The following is a description of a gene set: Human Gene Set: NRF2_Q4 studied in species Homo sapiens Genes having at least one occurrence of the motif NTGCTGAGTCAKN in the regions spanning 4 kb centered on their transcription starting sites. This matches the NFE2L2 transcription factor binding site V$NRF2_Q4 (v7.4 TRANSFAC)., and this is the list of marker genes: MGST1 (NCBI Gene Id 4257), PKN3, PFN2, ADCYAP1, KBTBD8, UBE2L3, CSNK1G2, PLEKHH3, CCDC126, LIMK1, TUBA4B, SH3BGRL2, WNT2, OGG1, MCF2, PAFAH1B1, PSMD1, S1PR1, MIDEAS, CLDN15, FGF12, KRT36, KCNH3, SOST, PSMA2, SYTL1, GPR21, LYSMD2, CRYBA2, UNKL, MMRN2, RB1CC1, EPHB2, LAMA3, BTK, MASP1, PPP2R2C, NECAB3, ADAM15, KCND1, NUDT10, CAPN12, RARG, RAB5IF, METTL2A, PPP2R2B, MAP2K1, BICDL1, SOBP, LINC00649, LGI3, PITPNC1, NUAK1, FGF11, MIA2, MYH14, FOXN1, GAPDH, PSME4, PSMD4, PPP1R9B, AKT3, ZFHX4, GK, SLC38A2, PSMD12, BEND7, SYNPO, NRN1L, INHA, TNRC6C, BACH1, FRMD4A, LAMC1, HSPA9, KCNA2, TMEM151A, TGIF1, GSE1, CACNB2, TLL1, USP13, BEX2 (brain expressed X-linked 2), VPS26A, SEC24D, TNXB, PSMA3, NR1D1, DRP2, PLEC, NDRG2, VCP, CCDC14, LOXL4, SEL1L3, TUBA1C, TBL1X, TREX1, SYT2, CRYGS, CDH23, CCDC186, REXO2, MNT, TFAP4, ESRRG, RGS2, GTF2A1, MSTN, MLLT11, CAPN6, ABCA2, RHOH, MDFI, SRPX2, MAPRE3, TENM3-AS1, SQSTM1, TEX19, EIF4G1, FGF1, SLC16A6, ETV5, HSP90AB1, TIAL1, MMP19, PER2, IDS, BAG2, LMO4, SLC11A1, HOXA3, SNCG, BCL9L, UCHL1 (ubiquitin C-terminal hydrolase L1), CLEC10A, DDX17, ZNF771, BAZ2A, ABCB6, ALS2, LIN54, DMD, CD44, MACO1, TOMM70, GAST, KRT33B, ALDOA, ABCD1, ENO1, JOSD1, PIAS1, UBXN4, SMPX, CELA1, WDR81, DTX2, PSMC5, CNTN6, TUBA4A, TECPR1, FBXO30, RAN, BNIP3, BRD2, RBBP7, BLMH, SFXN5, FCHSD1, APBA1, TUBB, MIR22HG, KIF5A, ATP6V0A1, NR5A1, ZIC1, EEF1A2, PHLDA2, CAB39, LRRFIP2, DUSP13B, COQ8B, SPTBN4, TTC1, MAST2, TXNRD1, F2RL2, PRX, RDH5, TFEC, WBP4 (NCBI Gene Id 11193), NRXN2, NOL4L, GAS2L1, ZIC4, CHP1, FGF9, CLC, ITM2B, ABHD4, PRR7, RAB6A, PDE4D, MINK1, ATP1B1, NUDT11, MAST1, IPO13, PSMD2, PPP4R4, SKP1, NOTCH4, YWHAG, RBM39, LINC02908, USP14, METTL2B, ITPKC, IL6, DCTN2, RABEP1 (NCBI Gene Id 9135), TBXAS1, ZC2HC1C, ARHGAP8, GADD45G, TBL1Y, EML3, LRP1B, CPNE8, MRPL32, CANX, XPOT, PSMD7, HSPG2, C6orf62, ROM1, EXD1, RTN3 (reticulon 3), GPX2, TFPI2, LRP1, CSMD3, SPTA1, H3-3B, EPB41L1, PDZRN4, CNBP, FLNC, SLC26A1, CDC42SE1, FTSJ3, ASS1 (argininosuccinate synthase 1), YIF1A, NOG, TMEM54, BLVRB, SMAD6, PRDM1